Given this list of marker genes RNU6-258P (RNA, U6 small nuclear 258, pseudogene), MTND1P14, SMCR5, SPECC1-DT, SLC47A1P2, ULK2, SMCR8, FTLP12, RNU6-468P, MTCO1P39, NCOR1, SLC5A10 (solute carrier family 5 member 10), TBC1D27P, TRPV2, RPL7AP65, KRT16P6, RN7SL426P, SNORD3B-1, RNASEH1P1, TOM1L2, DRC3, RNASEH1P2, RAI1, KRT17P2, ENSG00000228157, TMEM11-DT (TMEM11 divergent transcript), KRT17P5 (NCBI Gene Id 339240), SREBF1, FAM83G, AKAP10, SLC47A1P1, KCNJ12, ENSG00000250111, RAI1-AS1, SNORD3C, B9D1, UBB, MIR1288, SHMT1, NOS2P4, ATPAF2, RNU6-467P, RNU6-405P, TNPO1P2, RPS2P46, LGALS9B, FAM27E5, GRAPL-AS1, DRG2, PLD6, USP32P2, COTL1P1, RNU6-767P (RNA, U6 small nuclear 767, pseudogene), SNHG29, TNPO1P3, RPL17P43, GID4, FLII, SNORD3B-2, RNU6-1057P, FAM106A, TBC1D3P4, MTATP6P3, EIF1P5, ALDH3A1, MIR6778, SPECC1P2, MTCYBP13, BRI3P3 (brain protein I3 pseudogene 3), ENSG00000299826, CDRT15L2, KYNUP1, LINC02002 (NCBI Gene Id 105371595), CCDC144CP, ENSG00000264422, CCDC144NL-AS1, GRAPL, TRIM16L, NMTRQ-TTG12-1, SCDP1, FOXO3B, EPN2, SNORD65, MTND1P15, NCOR1P2, RASD1, MIEF2, RPL13P12, TSEN15P1, RPL21P121, UBE2SP2, SNORD49A, MPRIP, ENSG00000307831, RN7SL442P, FLCN, NMTRS-TGA3-1 (nuclear-encoded mitochondrial tRNA-Ser (TGA) 3-1), ZNF624, MAPK7, KRT16P5, ACTG1P24, RPL21P120, MED9, RNFT1P3, SPECC1, MIR1180, COTL1P2, ENSG00000235979, DHRS7B, TBC1D28, PAIP1P2 (PAIP1 pseudogene 2), RNU6-862P, MFAP4, MIR6777 (NCBI Gene Id 102465466), SNORA59B, LGALS9C, LLGL1 (NCBI Gene Id 3996), WEE1P2, HNRNPA1P19, LRRC75A, TOP3A, YWHAEP3, MAP2K3, LINC02088, LINC01563, KRT17P7, NOS2P3, SRP68P2, CCDC144BP, KRT17P4, TMEM11, KRT16P4, USP32P1, FBXW10, KCTD9P1, SRP68P3, ENSG00000212618, NEK4P2, KRT16P1, CCDC144A, LINC02094, SMCR2, LINC02076, OLA1P2, NDUFB4P3, FLJ36000, NATD1, ALDH3A2, MPRIP-AS1, YWHAEP2, SRP68P1, RN7SL775P, RN7SL620P, ZNF287, RNU6-1178P, LINC02090, ZNF286B, MYO15A, SNORD3A, GRAP, SNORD3D, UBBP4, SLC47A2, PDLIM1P2, EVPLL, MTCO3P13, NOS2P2, USP22, ENSG00000286743, FAM106B, FTLP13, KRT16P3, ZSWIM5P2, SLC47A1, KYNUP3, KRT17P6, KRT16P2, ENSG00000230709, RNF112, ENSG00000293001, CENPV, SRSF6P2, KRT17P1, CCDC144NL, SNORD49B, COPS3, PIGL, TNFRSF13B, LINC02693, KCNJ18, UPF3AP2, MTND2P12, USP32P3, RN7SL627P, MIR33B, MEIS3P2, MTND2P13, ENSG00000307344, PEMT, TVP23B, KYNUP2, PRPSAP2, ABHD17AP6, EPN2-AS1, UPF3AP1, MTND6P35, FAM106C, NT5M, TBC1D3P3, ALKBH5, here is a description of the gene set: Human Gene Set: chr17p11 species: Homo sapiens